Given this list of marker genes TOB2, EIF3A, MANF, REST, SRSF9, ZNF664, PRPF40A, CSNK1A1, SSR1, VPS36, MYO1B, PSMC6, BCLAF1, IER3IP1, SFPQ, HNRNPC, NFIA, ZNF462, PPHLN1, SMARCA2, IER2, LRPAP1, CANX, CTSO, CHD9, TNRC6B, NRIP1, ELOVL5, GCC2, EIF2AK2, SYMPK, TMED2, CDC37L1 (cell division cycle 37 like 1, HSP90 cochaperone), here is a description of the gene set: Human Gene Set: SCHAEFFER_PROSTATE_DEVELOPMENT_AND_CANCER_BOX4_DN Early prostate development genes (down-regulated at 6 hr dihydrotestosterone) which are also down-regulated in localized vs metastatic prostate cancers. Cancer cells differentiate along specific lineages that largely determine their clinical and biologic behavior. Distinct cancer phenotypes from different cells and organs likely result from unique gene expression repertoires established in the embryo and maintained after malignant transformation. We used comprehensive gene expression analysis to examine this concept in the prostate, an organ with a tractable developmental program and a high propensity for cancer. We focused on gene expression in the murine prostate rudiment at three time points during the first 48 h of exposure to androgen, which initiates proliferation and invasion of prostate epithelial buds into surrounding urogenital sinus mesenchyme. Here, we show that androgen exposure regulates genes previously implicated in prostate carcinogenesis comprising pathways for the phosphatase and tensin homolog (PTEN), fibroblast growth factor (FGF)/mitogen-activated protein kinase (MAPK), and Wnt signaling along with cellular programs regulating such 'hallmarks' of cancer as angiogenesis, apoptosis, migration and proliferation. We found statistically significant evidence for novel androgen-induced gene regulation events that establish and/or maintain prostate cell fate. These include modulation of gene expression through microRNAs, expression of specific transcription factors, and regulation of their predicted targets. By querying public gene expression databases from other tissues, we found that rather than generally characterizing androgen exposure or epithelial budding, the early prostate development program more closely resembles the program for human prostate cancer. Most importantly, early androgen-regulated genes and functional themes associated with prostate development were highly enriched in contrasts between increasingly lethal forms of prostate cancer, confirming a 'reactivation' of embryonic pathways for proliferation and invasion in prostate cancer progression. Among the genes with the most significant links to the development and cancer, we highlight coordinate induction of the transcription factor Sox9 and suppression of the proapoptotic phospholipid-binding protein Annexin A1 that link early prostate development to early prostate carcinogenesis. These results credential early prostate development as a reliable and valid model system for the investigation of genes and pathways that drive prostate cancer. from publication Schaeffer EM, Marchionni L, Huang Z, Simons B, Blackman A, Yu W, Parmigiani G, Berman DM (PMID 18794802) species: Mus musculus